Given this list of marker genes IGF1R, NSD3, SH2D3C, PRG3, PIGL, SYCP2, TRIM5 (tripartite motif containing 5), TUBGCP4, ST8SIA4, OSBPL2, GPBP1L1, PPP2CB, ITCH, EIF4A2, IFT140, RBM5, ST8SIA1, STAR, CD79B, SNX25, AVPI1, RGS12, ZMAT1, CPSF7, RASSF5 (Ras association domain family member 5), ZFAND4, INSM1, ELAC1, STK4, BCL11A, SLC12A6, FBXL3, FGD4, BLOC1S2, PRKCB, ENSG00000267882, PTGER3, IL36G, GCNT2, VAMP1, LTB4R, USP12, CRLF3, MMP8, MAP4K2, CHFR, JMJD1C, CREB1 (NCBI Gene Id 1385), COCH, DOCK5, BOD1L1 (NCBI Gene Id 57219), CARD6 (caspase recruitment domain family member 6), FUT4, IL31RA, MBTD1 (NCBI Gene Id 54799), NIPBL, UBE2E2, MAN2B1, GFRA2, C5orf34, L1CAM, PUM2, TNRC6B, MDM1, DNAJC7, ANGEL2, MARCHF3, SFT2D2, MAU2, ZFC3H1, TPRG1L, PBX1, KCNJ16, RNASE6, STK38, CEP63, GLIPR1, SPG11, DTX1, SLC25A27, ADAM23, FGD3, BZW2, KHNYN, HIGD1C, ARHGAP30, CD7, CBL, KMT2E, USP32, N4BP2L1, VCAM1 (vascular cell adhesion molecule 1), SEMA6D, PAXBP1, BMF, SLC4A1, HDC, ADAM19, SEPHS2, CHD2, SLC35A5, BANK1, NUFIP2, CREBRF, ROGDI, FAM107B, ZFX, LTB, MAPK8, NEDD9, HAUS8, TRAF3IP3, DPY19L1, MGST2, DNAJC28, IGSF6, ABCA13, MARVELD1, PDE7A, ATF7IP, CDC37L1 (NCBI Gene Id 55664), ARHGAP25, BMX, CXCR2, B9D2, RTL8C, FOXN3 (forkhead box N3), PRR5L, SUN2, DYRK2, GPR183, CACNA1S, MYO1H, LCOR, STX16, SUSD3, FAM167A, PPTC7, SPNS3 (SPNS lysolipid transporter 3, sphingosine-1-phosphate (putative)), VAMP5, APOC1, ZNF608, NLRP12, NR2C2, KCTD18, MAP3K5, KCNIP3, BRD9, BPGM, ZBTB16 (zinc finger and BTB domain containing 16, NCBI Gene Id 8070), AKAP13, SLC6A20, MED13, PPDPF (pancreatic progenitor cell differentiation and proliferation factor), HLCS, ELOVL5, FBRSL1, RHAG, RNF20, SAMSN1, BIRC2, KBTBD11 (NCBI Gene Id 9920), KMT2C, RYR3, TAF15, SERPINB7, RNF144A, DGAT1, AKNA, IL17RA, ADAM22, MTUS1, CNR2, CYP27A1, SLCO5A1, LBR, IKZF1, RASA3, UIMC1, ENTPD4, GRK6, ARHGAP4, AHSP, HTRA2, FAM13B, EPSTI1 (NCBI Gene Id 94240), CCR9, PI16, IL6R, FCN1, ICOSLG, COQ8A, IL18, CYFIP2, ADIPOR1, CD44, TIAM2, DAPP1, SCN3A, TMT1A, here is a description of the gene set: Genes up-regulated in monocyte-derived dendritic cells: untreated versus LPS like antigen from O. planktothrix (3h). Human Gene Set: GSE4748_CTRL_VS_CYANOBACTERIUM_LPSLIKE_STIM_DC_3H_UP A cyanobacterial LPS antagonist prevents endotoxin shock and blocks sustained TLR4 stimulation required for cytokine expression. We report the identification and biologic characterization of an LPS-like molecule extracted from the cyanobacterium Oscillatoria Planktothrix FP1 (CyP). species: Homo sapiens from publication Macagno A, Molteni M, Rinaldi A, Bertoni F, Lanzavecchia A, Rossetti C, Sallusto F (PMID 16717116)